Given this list of marker genes CRYZL1, PCDH7, SH3RF2, HOXD12, SGSM3, FAM227B, LGI4, CORO2B, TJAP1, DHFR (dihydrofolate reductase), TRAF3IP1, TMEM184A, SLC22A13, LUC7L3, RNF19A, DHX32, SPATA17, TRPC7, CORT, TM4SF1, LANCL2, DMWD, SOX30, ANKLE1, DAAM1, MARCHF10, KDM4B, PAK1IP1, FABP12, CCNF, ARHGEF10L, MOB2, PYROXD2, FRMD4A, SIRT1, GARIN1B, APIP, AIRIM, GNL3L, LRRC39, B3GNT3, SERTAD3, GCNT1, LEAP2, C4orf46, TP53BP1, RAD51C, TRIM23, SPACA4, EGR3, KNTC1, SLC22A14, ST3GAL4, USP32, USP6NL, EXOC4, SMARCA5, GAB1, CHURC1, FTMT, RB1, STAU1, FAM162A, TM4SF5, STAB1, C19orf18, FLVCR2, CEND1, SMOX, PBK, CDCA5, DENND2B (NCBI Gene Id 6764), DCK, SLC43A3, GHRHR, ATP5F1B, VWA3A, TWIST2, DIO2 (iodothyronine deiodinase 2), ZNF410, UBA7, VANGL2, LLGL1, NDP, FEZF1, ANKRD9, DCAF1, CCDC54, BLVRA, PGM5, GRM2, STRN3, MXD3, UROC1, CLTB, ICAM5 (NCBI Gene Id 7087), CYP8B1, CHAD, LRRC56, MAP4K5, BRCA1, ZFP2, XK, CARS1, KLRC2, NUDT17, HDAC6, SULT1B1, SIAE, IL17RE, CRYGS, GID8, SMC3 (structural maintenance of chromosomes 3), ECHDC1, RBMXL2, PMF1, OARD1, ELF4, KCNG4, KRTAP26-1, PIP5K1B, MRPL32, RCVRN, CTNND1, SULT6B1, KIF2C, RNF39, ERH, CLDN3, ZNF711, GEMIN7, WNT1, TERT, AP1B1, SRPX2, XAF1, GOLPH3L, DUOX1, ESPN, LPO, ME3, H2AX, SLCO1A2, SAT2, TTC14, ORC5, MRO, FOXL2 (NCBI Gene Id 668), DCAF10, CMPK2, SSX5, SLC1A4, HYPK (huntingtin interacting protein K), KRT8, NECTIN3, CARHSP1, IPO5, PCNT, ANO3, ELF2, GOLT1A, WDR81, HOXC6, AKAP7, TAPT1, CDH22, FAM174C (NCBI Gene Id 55009), CCNE1, PML, TIMM50, SASS6 (NCBI Gene Id 163786), CTCF, DIAPH3, GAREM2, POC1A, PRODH2, HYCC1, ELF5, STRAP, COL6A3, SYNGR1, SLAMF6, NAA40, FAM170B, PDE1C, ART5, NMRAL1, USP21, PANK2, SCLY, MUC4, IARS1, MYO19, TNFRSF10A, PRR11, PRNP, SLC44A4, ST3GAL6, ANAPC1, GSTA5, here is a description of the gene set: Human Gene Set: GSE27786_ERYTHROBLAST_VS_MONO_MAC_UP from publication Konuma T, Nakamura S, Miyagi S, Negishi M, Chiba T, Oguro H, Yuan J, Mochizuki-Kashio M, Ichikawa H, Miyoshi H, Vidal M, Iwama A (PMID 21540074) studied in species Homo sapiens Each fraction of mouse hematopoietic cells was purified by cell sorting from bone marrow of 8-week-old C57BL/6 mice, and its gene expression was analyzed. Genes up-regulated in comparison of erythroblasts versus monocyte macrophages.